The following is a description of a gene set: species: Mus musculus Mouse Gene Set: GOBP_COLUMNAR_CUBOIDAL_EPITHELIAL_CELL_DEVELOPMENT The process whose specific outcome is the progression of a columnar/cuboidal epithelial cell over time, from its formation to the mature structure. A columnar/cuboidal epithelial cell is a cell usually found in a two dimensional sheet with a free surface. Columnar/cuboidal epithelial cells take on the shape of a column or cube., and this is the list of marker genes: Xbp1, Fzd5, Tyms, Dicer1, Hoxa5, Hif1a, Cdh1, Cdkn1a, Bhlha15, Tlr9, Shroom3, Kcnma1, Pgr, Gsdmc2, Tmigd1, Prdm1, Tgfb1, C1galt1, Spdef (SAM pointed domain containing ets transcription factor), Gata2, Tigar (Trp53 induced glycolysis regulatory phosphatase), Gja1, Rarg, Mir203, Slc9a4, Rarb, Yipf6, Klf5, Yap1, Il6st, Mir7-1, Gpat4, Nkx3-2, Src (NCBI Gene Id 99351), Mir7-2, Ros1, Rara